The following is a description of a gene set: studied in species Homo sapiens Human Gene Set: chr7q21, and this is the list of marker genes: CDK6, CROT, RN7SL7P, RPS3AP26, GNGT1, RNU6-337P, RPL10P11, AKAP9, PDK4-AS1, SAMD9L, RBM48, TFPI2, MTHFD2P5, SEMA3C, ENSG00000227863, UFC1P1, FZD1, NDUFAF4P2, RNU6-1328P, CCZ1P1, NUP35P2, RUNDC3B, CACNA2D1-AS1, ASB4, PON2, MAGI2, PEG10, KPNA2P2, MIR5692C2, STEAP4, CFAP69, RNA5SP235, BET1-AS1, DYNLL1P7, RNU6-849P, RPS27P17, SRI-AS1, RPL7P30, HNRNPA1P8, DMTF1, RN7SL252P, SLC25A13, SEM1, CLDN12, RN7SKP129, MTERF1, GNAT3, CDHR17P, FAM237B, DDX43P3, PDK4, PEX1, MARK2P10, RAD23BP2, RN7SL478P, SOCS5P1, DDX3ILA1 (NCBI Gene Id 105375368), SDHAF3, MAGI2-AS3, ENSG00000305226, STEAP2-AS1, CYP51A1, HMGN2P11, ATP5PBP2, TEX47, BHLHA15 (NCBI Gene Id 168620), CALCR, GRM3, PPP1R9A, MIR489, SNRPBP1, PCLO, RNU6-530P, DBF4, AP1S2P1, PON1, DMTF1-AS1, HEPACAM2, ENSG00000233942, SGCE, GRM3-AS1, SEMA3D, RPL21P74, STEAP2, SAMD9, RNU7-188P, ENSG00000285964, HMGB3P21, KRIT1, TECPR1, RPL7AP40, LINC02932, ANKIB1 (NCBI Gene Id 54467), RN7SL869P, ARF1P1, MIR5692A1, ENSG00000207094, HNRNPA1P9, ADAM22, BET1, DLX5, TFPI2-DT, GRPEL2P3, LMTK2, RNU6-274P, MIR1285-1, ASNS, GTPBP10, GNAI1, DLX6-AS1, SLC66A2P1, NIPA2P1, HGF, BRI3, DYNC1I1, DLX6, ENSG00000287672, MAGI2-AS1, ENSG00000293394, TP53TG1, FAM133B, LRRD1, TAC1, RNU4-16P, MAGI2-AS2, EIF4EP4, CD36, RPL13AP17, GATAD1, GNG11, PTTG1IP2, STEAP1, RPS3AP29, RNA5SP234, MIR4652, RPS3AP25, CACNA2D1, SLC25A40, ABCB4, DPY19L2P4, ERVW-1, RN7SKP104, SNRPCP9, ZNF804B, MIR653, VPS50, TMEM243, RNU6-10P, LINC00972, RNU6-956P, SEMA3E, TMBIM7P, SRI, RNU6-364P, MIR591, HSPA8P16, PTP4A1P3, EIF4A1P13, ELAPOR2 (endosome-lysosome associated apoptosis and autophagy regulator family member 2), COL1A2, CYP51A1-AS1, RNU6-532P, PPP1R9A-AS1, OCM2, ABCB1, TVP23CP1, OR7E7P, VPS51P2, COX6A1P7, CDK6-AS1, RN7SL35P, HINT1P2, CDK14, CASD1, PON3, EEF1A1P28, OR7E38P, SEMA3A, LINC03017